Given this list of marker genes NDUFA7, NDUFA5, HSCB, NDUFAF5, NDUFC2, NDUFB11, NDUFA12, NDUFA6, NDUFA10, NDUFS8, NDUFB10, TIMMDC1, NDUFA11, NDUFB9, ACAD9, NDUFB8 (NCBI Gene Id 4714), MT-ND2 (NCBI Gene Id 4536), OXA1L, NDUFS3, MT-ND3, NDUFV2, NDUFB5, MT-ND6, LYRM2, NDUFA9, TMEM186, MT-ND4, NDUFAF3, NDUFS7, NDUFAB1, DMAC2, NDUFB1, FOXRED1, NUBPL, DMAC1, NDUFA8, NDUFC1, ECSIT, NDUFAF4 (NADH:ubiquinone oxidoreductase complex assembly factor 4), NDUFB6, NDUFV3, NDUFAF8, NDUFAF2, MT-ND1, TMEM126B, NDUFAF7 (NADH:ubiquinone oxidoreductase complex assembly factor 7), NDUFS1, NDUFV1, COA1, NDUFS4, HSPA9, MT-ND5, NDUFS5, PYURF, NDUFA3, NDUFAF6, NDUFB4, TMEM126A, NDUFS2, SFXN4, NDUFB3, NDUFAF1, NDUFB2, NDUFA1, NDUFB7 (NCBI Gene Id 4713), NDUFA13, NDUFS6, NDUFA2, here is a description of the gene set: Human Gene Set: REACTOME_COMPLEX_I_BIOGENESIS studied in species Homo sapiens Complex I biogenesis